The following is a description of a gene set: studied in species Homo sapiens Human Gene Set: GOBP_INTRACELLULAR_PHOSPHATE_ION_HOMEOSTASIS A homeostatic process involved in the maintenance of a steady state level of phosphate ions within a cell., and this is the list of marker genes: NHERF1, SLC34A3, FGF23, XPR1, SLC34A2, GCM2, ABCC6, UMOD, SLC34A1, ENPP1